The following is a description of a gene set: part of: Defensins Reactome Pathway: Beta defensins studied in species Mus musculus This event has been computationally inferred from an event that has been demonstrated in another species.<p>The inference is based on the homology mapping from PANTHER. Briefly, reactions for which all involved PhysicalEntities (in input, output and catalyst) have a mapped orthologue/paralogue (for complexes at least 75% of components must have a mapping) are inferred to the other species. electronically inferred by orthology from the curated human pathway, and this is the list of marker genes: Ccr6, Tlr1, Defb47, Defb42, Defb48, Defb43, Defb1, Defb21, Defb19, Defb18, Defb28, Defb25, Defb36, Defb14, Tlr2, Defb3